The following is a description of a gene set: Mouse Gene Set: GOBP_REGULATION_OF_NATURAL_KILLER_CELL_DIFFERENTIATION_INVOLVED_IN_IMMUNE_RESPONSE Any process that modulates the frequency, rate or extent of natural killer cell differentiation as part of an immune response. studied in species Mus musculus, and this is the list of marker genes: Zfp683, Pglyrp1, Pglyrp4, Pglyrp3, Pglyrp2